The following is a description of a gene set: species: Mus musculus The chemical reactions and pathways involving phosphatidylglycerols, any of a class of phospholipids in which the phosphatidyl group is esterified to the hydroxyl group of glycerol. They are important constituents of cell membranes. Mouse Gene Set: GOBP_PHOSPHATIDYLGLYCEROL_METABOLIC_PROCESS, and this is the list of marker genes: Pla2g6, Serac1, Hadha, Pla2g2c, Ptpmt1, Phb2, Pla2g5, Gpam, Crls1, Plscr3, Spata18, Pla2g2f (NCBI Gene Id 26971), Pla2g1b, Tafazzin, Tamm41, Slc27a1, Pla2g15 (phospholipase A2, group XV), Pla2g2e, Lclat1, Pnpla8, Pla2g4a, Dnajc19, Pla2g2d, Abca3, Pla2g3, Oc90, Plb1, Pla2g10, Mecp2, Pgs1, Pla2g2a, Them5